The following is a description of a gene set: studied in species Mus musculus from publication Lein ES, Hawrylycz MJ, Ao N, Ayres M, Bensinger A, Bernard A, Boe AF, Boguski MS, Brockway KS, Byrnes EJ, Chen L, Chen L, Chen TM, Chin MC, Chong J, Crook BE, Czaplinska A, Dang CN, Datta S, Dee NR, Desaki AL, Desta T, Diep E, Dolbeare TA, Donelan MJ, Dong HW, Dougherty JG, Duncan BJ, Ebbert AJ, Eichele G, Estin LK, Faber C, Facer BA, Fields R, Fischer SR, Fliss TP, Frensley C, Gates SN, Glattfelder KJ, Halverson KR, Hart MR, Hohmann JG, Howell MP, Jeung DP, Johnson RA, Karr PT, Kawal R, Kidney JM, Knapik RH, Kuan CL, Lake JH, Laramee AR, Larsen KD, Lau C, Lemon TA, Liang AJ, Liu Y, Luong LT, Michaels J, Morgan JJ, Morgan RJ, Mortrud MT, Mosqueda NF, Ng LL, Ng R, Orta GJ, Overly CC, Pak TH, Parry SE, Pathak SD, Pearson OC, Puchalski RB, Riley ZL, Rockett HR, Rowland SA, Royall JJ, Ruiz MJ, Sarno NR, Schaffnit K, Shapovalova NV, Sivisay T, Slaughterbeck CR, Smith SC, Smith KA, Smith BI, Sodt AJ, Stewart NN, Stumpf KR, Sunkin SM, Sutram M, Tam A, Teemer CD, Thaller C, Thompson CL, Varnam LR, Visel A, Whitlock RM, Wohnoutka PE, Wolkey CK, Wong VY, Wood M, Yaylaoglu MB, Young RC, Youngstrom BL, Yuan XF, Zhang B, Zwingman TA, Jones AR (PMID 17151600) Molecular approaches to understanding the functional circuitry of the nervous system promise new insights into the relationship between genes, brain and behaviour. The cellular diversity of the brain necessitates a cellular resolution approach towards understanding the functional genomics of the nervous system. We describe here an anatomically comprehensive digital atlas containing the expression patterns of approximately genes in the adult mouse brain. Data were generated using automated high-throughput procedures for in situ hybridization and data acquisition, and are publicly accessible online. Newly developed image-based informatics tools allow global genome-scale structural analysis and cross-correlation, as well as identification of regionally enriched genes. Unbiased fine-resolution analysis has identified highly specific cellular markers as well as extensive evidence of cellular heterogeneity not evident in classical neuroanatomical atlases. This highly standardized atlas provides an open, primary data resource for a wide variety of further studies concerning brain organization and function. Transcripts showing subcellular localization only to proximal dendrites in the adult mouse brain. Mouse Gene Set: LEIN_LOCALIZED_TO_PROXIMAL_DENDRITES, and this is the list of marker genes: Necab2, Atp5f1b, Ids, Mmd, Eps15, Map1a, Rph3a, Slc17a7, Snrpn, Aco2, Kif5c, Chgb, Cdk14, Ina, Hpca, Tmsb4x, Nrgn, Sult4a1, Bsn, Map1b, Mtch1, Gpd1, Ank2, Rad51, Rnf10, Eef1a1, Dnajc6, Nnat, Plppr2, Snurf, Gfm2, Neto1, Lynx1, Selenow, Nsg2, Kifc5b, Map2 (NCBI Gene Id 17756)